The following is a description of a gene set: studied in species Homo sapiens Human Gene Set: REACTOME_GLYCOSAMINOGLYCAN_METABOLISM Glycosaminoglycan metabolism, and this is the list of marker genes: GPC5 (glypican 5), CHST1, IDUA, B3GNT3, DSEL, B4GALT2, VCAN, HS3ST4, DCN, NDST4, GLB1L2, HAS3, SDC3, HS6ST2, SDC4, HPSE, HS3ST2, B3GALT6, EXT1, B3GNT2, HS3ST6, SLC35B3, CHST5, GUSB, PRELP, ST3GAL1, GPC3, HYAL3, XYLT2, CHST14, CHST6, CD44, SGSH, GLCE, ST3GAL3, UST, HEXB, CHST3, DSE, SLC35B2, B3GAT3, ABCC5, BGN, OGN, CSPG5, GNS, HEXA, NDST2, HPSE2, B4GALT5, CHSY1 (NCBI Gene Id 22856), B3GAT2, SLC26A2, NCAN, GPC4, GALNS, HS2ST1, CSGALNACT2, BCAN, CHST11, CHST7, B4GALT1, CHPF, B3GAT1, GLB1L3, B4GALT3, STAB2, GLB1, SLC35D2, UXS1, HS6ST3, HYAL2, B4GALT4, HS3ST3B1, CHSY3, B4GAT1, GLB1L, SDC1, KERA, OMD (NCBI Gene Id 4958), LYVE1, HAS1, NDST1, ST3GAL4, ARSB, B4GALT7, GPC6, FMOD, HGSNAT, ST3GAL2, CHST9, HS3ST3A1, HS3ST5, CSPG4, B3GNT4, SDC2, SLC9A1, CHST13, GPC1, CHPF2, HS3ST1, HMMR, B3GNT7, B4GALT6, PAPSS2, NDST3, HYAL1, GPC2, ACAN, LUM, PAPSS1, CHST15 (NCBI Gene Id 9916), ST3GAL6, XYLT1, CHST12, IDS, SLC26A1, NAGLU, HAS2, CSGALNACT1, EXT2, CHST2, CEMIP, AGRN, HS6ST1, HSPG2, CHP1